Given this list of marker genes NDUFC2 (NCBI Gene Id 4718), MT-TN, LETM1, CTLA4, TIMMDC1, LMOD2, IGHM, TYMP, ZBTB24 (NCBI Gene Id 9841), DGCR8, PNPT1, IFIH1, NUBPL, LIAS, MECP2, CARMIL2, TEFM, ESCO2, CAMKMT, FANCE, IL12A, PRF1, SASH3, GTF2H5 (NCBI Gene Id 404672), SQSTM1, IRF8, TTN, DCLRE1C, STXBP2, CD55, COX16, SEC23B, NDUFAF4, MT-TW, TSFM, CPT2, SYK, AARS2, ACADVL, FANCC, IL21R, OCRL, LCK, NDUFAF8, BCS1L, SMARCAL1, RRM2B, KRAS, DSG1, CLCN7, RFXANK, SFXN4, KLHL24, POLE, CD27, AIFM1, FOXRED1, MMP1, PIGA, CSNK2A1, SON, UNG, TRMT10C, BRIP1, GTPBP3 (GTP binding protein 3, mitochondrial), CD3E (NCBI Gene Id 916), MT-CO3, SP110, GFM1, RACGAP1, SLF2, MTRFR, TBX1, RHAG, WEE2, ATP5F1D, MYH7, VPS45, MT-TQ, DSP, KCTD7, PDGFB, CCND1, MRPS23, FAT4, DOCK2, RFX5, HIBCH, PDP1, FMR1, KRT14, MT-ND6, AKT1, COX6A2, DDB2, MCPH1, SCO1, IBA57, NSD2, NDUFA9, TNFRSF1B, RRM1 (NCBI Gene Id 6240), STAT5B, WIPF1 (NCBI Gene Id 7456), NDUFB3, MYSM1, RBM8A, HIRA, CCBE1, TONSL, DNAJC30, ATPAF2, BAP1, IKZF1, KDM6A, CARD11, ZMPSTE24, REL, TARS1, RPA1, AGK, SLC39A8, DNA2 (NCBI Gene Id 1763), TRIT1, ACAD8, GLRX5, ZFTA, ACAD9, NDUFA1, SKIC3, CD40LG, RAC2, NDUFS2, ICOSLG, RAD51, CDAN1, FDXR, TERT, RIPK1, LIG1, GATM, PRKCD, UQCC3, FANCD2, CD79A (CD79a molecule), COG6 (component of oligomeric golgi complex 6), FH, CYC1, LYN, NDUFV2, COA6, SLC25A26, TTC19, ATP6AP1, SLC25A13, EARS2, RNF113A, PREPL, NDUFB10, NSMCE3, SAMD9L, ECHS1, IL2RB, POU2AF1, NFKB1, ERCC8, CD247, MCOLN1, TNPO3, ADAMTS3, AHDC1, UQCRH, COX5A (NCBI Gene Id 9377), PTPRC, SLC7A7, PSMB10, BACH2, MTHFD1, MPV17, NSUN3, TOP3A, MDM4, CDK5 (NCBI Gene Id 1020), SHH, TNNI3, NF2, BUB1B, MRPL39, TNFRSF11A, CARD10, MS4A1 (membrane spanning 4-domains A1), GP1BB, SFTPA2, PET117, PRIM1, JAK3, HGSNAT, SDHD, MT-ND1, PSAP, STING1, PEX6, CAVIN1, CHKB (choline kinase beta), ATM, CENATAC, B2M, COX4I1 (cytochrome c oxidase subunit 4I1), CD3D, MT-CO2, IKBKG, MYH14, ISCA2, FAS, ORAI1, PIGG, TNFRSF11B, HELLS, CTNNBL1, IRF1, DEAF1, CARD9, MOGS, HLA-DQB1, RMRP, SCARB2, ADA2, XRCC2, ATP6AP2, TMEM185A, PGM3, PIGM, MRPS16, CYBA, CXCR4, FANCL, LIG3, ARHGEF1, MTOR, CA2, RFWD3, SFTPC, PEPD, NDUFS7, HMGCL, CD3G, CPLX1, SMARCE1, TMEM126B, GATA3, ITCH, CD81, IGLL1, ZAP70, IRF5, CYBB, LYRM4, ZEB2, NFE2L2, MRPL12, DNM1L, KARS1, HSD17B10, PIK3CD, UFD1, ACD, IL17RA, SUN5, PLVAP, TRMT5, XIAP, PIGK, DNMT1, TIMM22, GBA1, TIMM50, GATC, DGUOK, UQCRB (ubiquinol-cytochrome c reductase binding protein), AP3B1, FNIP1, RNU4ATAC, ZP1, NDUFA13, NAXE, PDCD1, FANCG, POLD1, NKX2-5 (NCBI Gene Id 1482), FDX2, WRAP53, DOCK11, CLN5, NDUFA10, NDUFB9, PSMB8, SUCLA2, VCP, WAS, SPINK5, PNP, TMEM70, CDSN, DRG1, TUBB8, STAT1, MECR, CCNO, SLC46A1, MTO1, ETFDH, ATP5F1E, PUS1, STX11, FOXN1, MCM10 (NCBI Gene Id 55388), FLII, DGCR6, MAN2B1, MT-TL2, NLRP1, EPG5, CORO1A, SLX4, GTF2E2, MAD2L2, TWNK, CASP10, PDHB, TNFSF12, ITK, SLC3A1, QRSL1 (glutaminyl-tRNA amidotransferase subunit QRSL1), NFKB2, MRPS22, NDUFS1, COA5, NDUFB7, TRMU, ETFB, TIMM8A, OTULIN, CD40, TNFRSF9, STAT2, DLD, MYD88, LIG4, UMPS, TLR8, SEC61A1, SPG7, TBK1, PTEN, POLG2, CISD2, OPA1, NDUFA6, ZNF341, SLC25A10, IL2RG (NCBI Gene Id 3561), DGCR2, MSN, SH3KBP1, NDUFS6, TAFAZZIN, NDUFS4, RTEL1, CTPS1, NDUFA2, NDRG1, MRTFA, COX20, MT-TL1, IGKC, NDUFAF3, STAT3 (NCBI Gene Id 6774), TOM1, KRT9, PATL2, MPLKIP, GGPS1, BTK, FXN, CD320, NDUFA8, MT-TF, MT-ND4, MRPS14, ALG12, NHLRC2 (NCBI Gene Id 54835), HLA-DQA1, CD79B, ZCCHC8, PALB2, NFKBIA, ADAM17, COL7A1, KNSTRN, SIK3, IL12RB1, PIK3CG (phosphatidylinositol-4,5-bisphosphate 3-kinase catalytic subunit gamma), HYOU1, TNNT2, MT-TH, STIM1, FCGR3A, KIF23, SHARPIN, NARS2, DEF6, FANCB, DNAJC21, LEPR, RAD51C, MT-ATP6, MGME1, TAMM41, ERCC5 (NCBI Gene Id 2073), SLC5A6, SH2D1A, NDUFAF5, GNE, PLCG2, UBE2T, PPM1B, NDUFAF2, AARS1, IFNGR1, FASLG, GFM2, MRPS25, CNBP, AICDA, DCLRE1B, CR2, ERCC6, STAT6, TNFRSF13C, EXTL3, IVNS1ABP, MT-TE, NFS1, ERCC2, DLAT, IRAK4, ATXN2, KLHDC8B, PARN, TINF2, SLC39A4, PDHA1, PNPLA2, CRLS1 (cardiolipin synthase 1), KMT2D, SLC25A20 (solute carrier family 25 member 20), NDUFAF1, MUC5B, SDHB, ESS2, MT-ND2, TPP2, NCKAP1L, SLC25A4 (solute carrier family 25 member 4), CASP8, GJA1, NDUFAF6, IRF2BP2, POMP, ERCC4, CD70, GPC4, COL1A1, UHRF1, NFU1, LRPPRC, PIK3R1, SUFU, SEC24C, IL7R, MRE11, RFXAP, AFG3L2, LAMTOR2, COA3, HACD1, NEB (nebulin), IGHG2, PSMB9, CLN3, ACTC1, XPC, OAS1, RAG1, TPP1, JMJD1C, ARPC5, SCN4A, FUS, BCL10, SLC19A1, NDUFA11, NDUFA12, RAD50 (RAD50 double strand break repair protein), MT-CYB, SPIB, NLRC4, MAP3K14, NOP10, FLNA, TTC7A, CHCHD10, UQCC2, CACNA1S, ACTN2, ASAH1, MFF, LCP2, TSC1, SPI1, SRP54, MALT1, MCTS1, MGAT2, NHEJ1, NAE1, DNAJC5, SLC2A1, CLN8, TCF4, LRRC8A, IKBKB, COQ4, RARS2, TRIP13, C1QBP, UVSSA, TNFRSF13B, CARS1 (NCBI Gene Id 833), DOCK8, AK2, SETX, MT-ND5, NDUFS8, POLD3 (DNA polymerase delta 3, accessory subunit), DNMT3B, MMEL1, SLC35C1, MST1, CIITA, RNF31, MIEF2, CARS2, PIGT, TRNT1, LRBA, COA8, ACADM, SLC25A3, PDHX (pyruvate dehydrogenase complex component X), HLA-DRB1, BRCA2, RAG2, ATP5F1A (NCBI Gene Id 502), TCN2, SCO2, MCCC2, UQCRQ, MCM4, RYR1, PIK3C2A, EHHADH, FANCA, RAB27A, RASGRP1, NELFA, ISCU, NPC1, ELANE, LRP5, PANX1, ERCC3, ELAC2, ARSA, GYG1, RAI1, HADHA, NDUFV1, TFAM, NRAS, MT-ND3, CYP27A1, LYRM7, IQSEC2, TARDBP, TXN2 (NCBI Gene Id 25828), KRT74, ARVCF, FANCF, MT-CO1, RNF168, TFRC, POT1, SEMA4D, IPO8, NADK2, ALPK3, MRM2, FANCI, NEUROG3, ICOS, PMM2, VCL, MT-TS2, LEP, SMO, UNC13D, YARS2, TYMS, MVK, FANCM, CDCA7, TRAF7, TK2, TP53, NDUFS3, NDUFB8, SLC34A1, SPPL2A, MTFMT, IL6ST, NDUFB11, ZP2, PTCD3, GFER, PET100, CD28, VPS33A (NCBI Gene Id 65082), FLAD1 (flavin adenine dinucleotide synthetase 1), SKIC2, GNPTAB, PSTPIP1, NBN, TNFSF15, PMFBP1, PSMB4, SDHA, ADA, SLC39A7, SUCLG1, TGFB1, TYK2, CTNS, LMNA, CLN6, RPL3L, IL21, GPR35, GPC3, LBR, MT-ND4L, EGFR, TCF3, ALB, FBXL4, CBLB, FOXP3, BLNK, XPA, CD19, LAT, BOLA3, COMT, CTBP1, IL2RA, ETFA, HADH, IL6R, POLG, VARS2, XRCC4, BLM, RREB1, GNS, NDUFA4, SLC22A5, KRT5, MAGT1 (magnesium transporter 1), PEX5 (peroxisomal biogenesis factor 5), BRCA1, SMARCB1, DOLK, TET2, PIK3CA, here is a description of the gene set: An anomaly of cellular morphology or physiology. species: Homo sapiens Abnormal cellular phenotype Human Gene Set: HP_ABNORMAL_CELLULAR_PHENOTYPE